The following is a description of a gene set: Any apoptotic process in a B cell, a lymphocyte of B lineage with the phenotype CD19-positive and capable of B cell mediated immunity. Mouse Gene Set: GOBP_B_CELL_APOPTOTIC_PROCESS studied in species Mus musculus, and this is the list of marker genes: Myc, Bcl2, Mir363, Cd24a, Pkn1, Lyn, Il2, Slc39a10, Traf3ip2, Fnip1, Mir18, Mif, Ormdl3, Mir17, Mir19b-2, Bcl2a1a, Ada, Noc2l, Mir106a, Mir19b-1, Mir20a (microRNA 20a), Hsh2d, Mir19a, Mir93, Tnfrsf21, Il3, Pdcd1, Crkl, Bax (BCL2-associated X protein), Nfkbiz, Bcl10, Bak1, Il21, Cd74, Cd44, Mir106b, Mir92-1, Mir92-2, Irs2, Aurkb, Pten, Mir18b, Mir25, Mir20b, Foxp1 (NCBI Gene Id 73231), Il10